The following is a description of a gene set: species: Homo sapiens The aim of this study was to identify genes regulated by IL-12, IL-18 and IFN-alpha during early differentiation of human Th1 cells from publication Filén S, Ylikoski E, Tripathi S, West A, Björkman M, Nyström J, Ahlfors H, Coffey E, Rao KV, Rasool O, Lahesmaa R (PMID 20304822) Genes down-regulated in the activated CD4 T cells (48h): IL-12 versus IL-12 and IL18. Human Gene Set: GSE20198_IL12_VS_IL12_IL18_TREATED_ACT_CD4_TCELL_DN, and this is the list of marker genes: NRAS, EIF4ENIF1, ARIH2, LARP4B, ZMIZ1, ANGPTL1, PPM1F, ARHGAP21, STIM2, PIP5K1B, RPL3, TMEM86B, DPF2, GGH, SLC25A6, SLC12A7, RFTN1, TSPAN17, TTC4, HNRNPUL2, USP24 (ubiquitin specific peptidase 24), ATP13A3 (NCBI Gene Id 79572), USP54, LMO4, MBD1 (methyl-CpG binding domain protein 1), AP3M2, PHAF1, C12orf43, PATJ (NCBI Gene Id 10207), TESK1, RABIF (RAB interacting factor), WWP2, AAMP, SERINC3, SSBP2, ABCB4, NRF1, CHD1, PLEKHA5, ARHGAP1, LYN, KCTD10, HMGCR, GNA11 (NCBI Gene Id 93626), TNPO1, AMFR, WDR37, STX16, LSM14A, FBXO25, SCML4, QSOX2, MEMO1, NFYC, TOPBP1, DDX46, MAPK9, ADI1, MMAA, MPC1, DNAH8, CTSE, DYRK2, DFFA, AKAP13, PLEKHA3, FAR1, XYLT2, MBP, RHAG, TSNAX, PLEKHM1, DTWD1, GPATCH8, EED, PPM1G, MAPK1, VIM, MAP7D1, IBTK, PHF10, VPS33B, MZB1 (NCBI Gene Id 51237), POLK, GRINA, BMP2K, SAV1, FBXO31, CUL4A, PHC2, ATP9B, PSIP1, LONRF1, CD247, CDK4 (cyclin dependent kinase 4), GCLM, IDS, VPS26C, HRAS (NCBI Gene Id 338029), ZXDC, PAG1, CLCF1, CD81, ARID5B, CYBB (NCBI Gene Id 1536), DYNLT1, HNRNPA3, LRP6, IFITM10, DGKA, PTPDC1, TCAIM, ABI1 (NCBI Gene Id 10006), BAG3, DUSP2, DCAF1, FAM209A, ERAL1 (Era like 12S mitochondrial rRNA chaperone 1), CREBL2, B3GALNT1, STXBP3, NFATC2, MAPK1IP1L, SH3BP5, NAPSA, DNAJC3 (DnaJ heat shock protein family (Hsp40) member C3), P2RY13, DOCK6, SLC16A6, LAIR1, CD44, IFT74, RPL9, CISD1, HSD17B4, SSRP1, PI4K2B, CTDSP1, PLEC, ANKRD40, CXXC5, DCAF7, TSPAN4, CLCN7, RGCC, IRF2BP1, LAMB3, ACACA, HEG1, BRD9, ESRP2, KDM2B, PML, ACE, PRC1, FRMD4B, IFFO1, SEC22C, TXN (thioredoxin), CDV3, NOXO1, MLEC, RIT1, FSTL1, HCK, TMEM129, RASSF4 (Ras association domain family member 4), UTP11 (NCBI Gene Id 51118), ST8SIA6, PTTG1IP, DCUN1D1, KLF3, DLG3, GDPD3, CTC1, CDC27, TRAPPC10, CCAR1, OSBPL9, PGGT1B, POMGNT1, FAM193A, FBXL17, QKI, TTF2, CNR2, DHRS13, RIPK4, PDE3B, GPI, ARHGAP25, TRAK2, RNPEP, UBR1, REV1, SUMO3, ABHD3, RPL18A, RBM22, ABCG1